Given this list of marker genes Ltbp1, Dand5, Cer1, Nrros, Fbn1, Grem2, Grem1, Nbl1, Zfp653, Cd46, Fbn2, here is a description of the gene set: Mouse Gene Set: GOBP_EXTRACELLULAR_REGULATION_OF_SIGNAL_TRANSDUCTION Any regulation of signal transduction that takes place in the extracellular region. studied in species Mus musculus